Given this list of marker genes NT5C, UCK1, UPRT, UCKL1, NME1, AK3, DHODH, NME4, DPYS, CDA, CTPS1, DPYD, CTPS2, ENTPD5, NME5, NME2, NME7, AK5, UPP1, UMPS, NME9, UPB1, NME2P1, CMPK1, AK9, NME3, UPP2, CAD, ENTPD7, UCK2, ENTPD4, NME6, DCK, here is a description of the gene set: Human Gene Set: GOBP_PYRIMIDINE_RIBONUCLEOTIDE_METABOLIC_PROCESS species: Homo sapiens The chemical reactions and pathways involving a pyrimidine ribonucleotide, a compound consisting of nucleoside (a pyrimidine base linked to a ribose sugar) esterified with a phosphate group at either the 3' or 5'-hydroxyl group of the sugar.